The following is a description of a gene set: species: Mus musculus Reactome Pathway: Activation of RAC1 downstream of NMDARs This event has been computationally inferred from an event that has been demonstrated in another species.<p>The inference is based on the homology mapping from PANTHER. Briefly, reactions for which all involved PhysicalEntities (in input, output and catalyst) have a mapped orthologue/paralogue (for complexes at least 75% of components must have a mapping) are inferred to the other species. electronically inferred by orthology from the curated human pathway part of: Post NMDA receptor activation events, and this is the list of marker genes: Camkk2, Calm1, Camk1, Camkk1